The following is a description of a gene set: studied in species Homo sapiens Human Gene Set: GOBP_ENZYME_LINKED_RECEPTOR_PROTEIN_SIGNALING_PATHWAY The series of molecular signals initiated by an extracellular ligand binding to a receptor on the surface of the target cell, where the receptor possesses catalytic activity or is closely associated with an enzyme such as a protein kinase, and ending with the regulation of a downstream cellular process, e.g. transcription., and this is the list of marker genes: HDAC6, GIPC1, CDK5R1, MIR519D, PIK3R1, NRTN, USP9X, SH2B3, FGFR2, BLK, PDGFRA, EP300, CD109, MIR296, SH3GL2, NDN (necdin, MAGE family member), BLVRB, BCAR1, ZDHHC16, TRIM33, CCBE1, STAP1, NPPC, ERCC2, USP9Y, DLX3, PHIP, GRB14, IL1R1, LRIT3, IGF1, PLCG1, IGFBP4, CCN3, PDE6H, EFNB2, FSTL5, FOXD1, RALB, FBXW7-AS1, ADRA2A, HIP1R, SFRP4, KCP (NCBI Gene Id 378173), ERRFI1, CEACAM1, RNF115, SOCS1, ING2, ELAPOR2, SMAD3, PAK2, SHC4, ILK, FRS2, KL, ARID4A, FGF17, AP3S1, LEMD3, MIR885, FERMT1, EPHA1, FARP1, HTRA1 (HtrA serine peptidase 1), GIGYF1, GHRL, MIR146A, RET, KIT, ADIPOQ, CSRNP1, WNT5A, MIR497, MIR149, SDCBP, SPRED1, ENG, WWTR1, ZMIZ1, NPTN, TMEM204, ADAMTS12, FGFBP3, RASA1, SFRP1, PIK3R3, PIAS2, MIR29B1, SMAD7, CYFIP2, ACP4, ERBIN, MYO1E, MIR1271, WNT1, SNX25, GHR, CD3E, COL4A3, PIK3CD, MIR101-1, FOS, MTSS1, FST, NAMPT, TGFBRAP1, FAM89B, BRAF, SMOC2, RAB14, CEP57, TBX20, KDR, DAND5 (DAN domain BMP antagonist family member 5), LRRC32 (leucine rich repeat containing 32), RGMA, MEGF8, MYORG, WFIKKN2, ZYX, VEGFC, SOSTDC1, FOXO1, GSK3B, RTN4, ETV2, RAF1, HIVEP1, MAP3K7, FOXO4, C1QTNF12, CRIM1, SHCBP1, MIR210, HSPA5, IL12B, PDGFD, USP15 (ubiquitin specific peptidase 15), RYK, HFE, GRB10, PDE6G, MIR23A, LIFR (LIF receptor subunit alpha), MSTN, GUCY2F, JAK1, CYFIP1, VAV1, RHOQ, RABGEF1, HIF1AN, NR2F2, AKT2, FOLR1, RAB7A, SHH, MYOC, RPS6KB1, IL1B, PTPRF, JCAD, FGF16 (fibroblast growth factor 16), DACT2, RBPMS, TGFA, DLX5, GALNT3, PXN, TSC22D1, SH2B1, ARHGEF7, SESN3, PDGFRL, MIR424, BDKRB2, FYN, ANKS1B, TRIB3, EFS, NUS1, RBBP4, CD8B, FLT3, FGF6, SHISA2, ACVR1C (activin A receptor type 1C), SMAD5-AS1, IL17F, HIPK2, GDF11, VWA2, MIR26A1, MIR140, CSF1, IFT80, FGFBP1, PRDM14, ABL1, SIRT1, TYK2, EPHA10, RPS6KB2, PIP4K2C, NEDD4, ENPP1, CADM4, ZNF8, UCMA, FGF20, FKBP8, COL1A1, HNF4A, ZEB2, ZNF703, CNKSR1, SREBF1, MAPKAPK3, MIR183, XBP1, PILRB (paired immunoglobin like type 2 receptor beta), SELENON, ARRB2 (NCBI Gene Id 409), NKX3-1 (NCBI Gene Id 4824), ONECUT2 (NCBI Gene Id 9480), NPR1 (NCBI Gene Id 4881), PDGFB, FGF2, SULF2, MMP14, SLC39A14, VEPH1, MIR181A2, PML, KLB, FGF8, FGF12, HGF, TMEM100, INHBA, MTCL2 (microtubule crosslinking factor 2), HGS, SAMD10, MSX1, SAP30 (NCBI Gene Id 8819), PROX1, STAT6, SAMD12, MUSK, POLR1G, CAV2, ARK2C, MIR573, MVB12B, TGFB3, GDF7, TRIM71, GRB7, CSH1, EFNA4, PPM1L, MEN1, CTDSPL2, GPER1, PHF14, ADAMTS3, IFI6, WFIKKN1, VEGFA, PRICKLE1, SMURF1, NODAL, NEDD9, AKT1, SOST, DUSP3, FERMT2, AGR2, SNX5, PTPRE, PIN1, LRP1, HSPB1, ZNF451, NUP93, NCOA5, FGF4, TMEM119, ZEB1, MAPKAPK2, MIR98, UBASH3B, BCL9, NRP2, TGIF2, AGTR2, CCN2, CAV1, MIR1224, IGF2R, PIP4K2B, BDNF, SMARCC1, RBBP7, TGFBR3, HES5, ABI1, TSPAN9, ITGB1, APC, FBXW7, TGFBR3L, ERBB4, ARID5B, PRKCD, MIR498, GHSR, SPRY4, PIP4K2A, BLNK, IL31RA, FAM83B, APOA1, SPRY2, BMP4, PTP4A3 (protein tyrosine phosphatase 4A3), FGF23, TAB1, NRG4, HHEX, MIRLET7B, MBD5, MIR27B, TSC2, ZC3H3, ADISSP, NHERF1, TGFB2, MMRN2, MIR564, MIR373, PLAUR, CD4, GAREM1, NRROS, LRP2, DLX1, LEPROT, PIK3CB, SPTBN1, MTOR, COL4A5, HRAS, NTRK3, LONP1, RAPGEF2, EPHB1, HTRA4, GFRA4, BRMS1, GLG1, PPP2R5B, PARP1, STXBP4, SNCA, CSF1R, APPL1, JAK2, SLC2A10, CSHL1, FGF21, LATS1, VEGFD, TWSG1, ALKAL1, IGFBP3, CDH13, TYRO3, NLK, CASS4, GAB2, SKOR1, GP6, KIF16B, BMP2, CSH2, BRMS1L, SH2B2, RNF111, PDK2, NTRK2 (NCBI Gene Id 4915), CCN1, PIK3C2A, TGFBR1, CDKN1C, EPHA7, EFEMP1, PTPN2, GAB4, MIR19B1, MYO1C, SLC27A4, SMURF2, TNXB, GPRC5A, RAC1, INS, AKT1S1, LCK, EFNA5, SFRP2, EPHB6, ADGRG1, NTF3, DCN, EGR1, FOXC1, STK11, CLNK, SPG21, CER1, SMAD9, PDK4, FSTL1, DSTYK, GCNT2 (NCBI Gene Id 880), NHERF4, EFNB3, MIR205, MIR199B, TET1, SLC2A4, IRS1, CHRDL2, RUNX2, DAB2, GFRA3, ALKAL2, DOK5, VAV2, CSF2RA, PRMT1, SINHCAF, ZDHHC17 (zinc finger DHHC-type palmitoyltransferase 17), LCP2, TMEM53, IL6ST, LEP (NCBI Gene Id 3952), SOCS2, NRG3, MMP2, HIP1, DDX5, CDKN2B, SRMS, TGIF1, SERPINA12, VTN, ID1, EREG, EGF, TIE1, CSNK2B, KALRN, DOK2, ACVR2B, TTK, IL17RD, SCX, IL12A, BAMBI, FZD1, AXL, SAP30L, EPHA5, APOD, ZNF423, INSR, FGFR3 (NCBI Gene Id 55546), CD7, CCDC88A, MAPK3, CAV3, NCK2, DDR1, LRIG2, EGFR, DBX2, HSPA1A, GDF10, ZGPAT, LIF, EFNA2, VPS13A, GUCY2D, OFD1, MTMR4, EIF2AK3, ITGB3, AHI1, HPGD, ARF4, PTPRR, JUN, MMP9, PMEPA1 (prostate transmembrane protein, androgen induced 1), MIR361, MAPK1, MIR638, DSG4, NUMA1, PEG10, IGF2, FGF14 (NCBI Gene Id 317685), TMPRSS6, FFAR3, FLRT1, PRLR, PBLD (NCBI Gene Id 64081), MET, PAK3, SNX6, VWC2, RHBDF1, ITGA8 (integrin subunit alpha 8), ITGA5, PDCD4, HAP1, GPC1, NUCKS1, AMH, WASF1, GFRA1, MIR29C, MIR103A1, NR4A3, TFAP2B, GH1, TIAM1, FGFRL1, PTN (pleiotrophin), ERBB3, PPARG, EPN2, SRC, RGS14, DKK1, GDF2, SH3TC2 (NCBI Gene Id 79628), SOCS4, STON1, INPPL1, TGFBR2, RBM4, PDGFRB, GATA4, NDRG4 (NCBI Gene Id 65009), CTNNB1, MIR490, MZB1 (marginal zone B and B1 cell specific protein), FGF7, LTBP2, SOCS3, PTPRJ, CRIPTO3, CFC1B, NRXN1, RGCC, SORT1, EPHB4, NUP62, EID2, CITED1, ARNT, ROR1 (receptor tyrosine kinase like orphan receptor 1), EPHA8, MIR93, PIK3R2, MIR520C, SOS2, MAPK14, FGF9 (NCBI Gene Id 2254), RHBDF2 (NCBI Gene Id 79651), CRK, HIF1A (NCBI Gene Id 3091), BECN1, SPRY1, PTPRD, GHRHR, COL4A6, FKBP1C, PTPRT (protein tyrosine phosphatase receptor type T), GSK3A, APLN, LATS2, NDP, INTS9, ZNF592, RAPGEF1, CBLB, PRDM16, ING1, PDPK1, ZFYVE9, PTPN1, MIR204, TNFAIP6 (NCBI Gene Id 7130), HOXA13, LOX, ADIPOR1, GREM2, CIDEA, MYOCD, NCL, MIR323A, MIR372, FGF5, EFNB1, PSG9, EIF4EBP2, STAT3, SLC2A8, AKAP4, SKI, MMRN1, PSPN, GDNF, RELA, ANGPT1, MIR30A, GFRA2, NOG, SOCS7, ATXN1, GLCE, DOK1, CD63, IRS2, ZMIZ2, CBL, ABL2, ALK, SH2D6, FAM83G, TGFB1, SYK, GUCY2C, NTRK1, APPL2, HRG, NR1H4, VPS25, SHOC2, PTPN18, COL1A2, F3, DDR2, FOXC2, FZD4, NOTCH1, TXNIP, CD8A, ATOH8, COL4A1, PTPN12, CFC1, LPXN, GAS6, NGF, SKOR2, ACVR1, MICOS10-NBL1, PTPRG, SMAD2, FURIN, FUT8, MIR10B, SHC2, AR, LEPROTL1, IFT20, HCK, MIR142, ROR2, DOCK3, SEMA6A, DAB2IP (DAB2 interacting protein), GDF15, NPPB, HDAC2, EPHA2 (NCBI Gene Id 1969), F7, TEK, IQGAP1, MSX2, MIR302C, EXT1, PTPRK, TNS2, SMPD3, PALS1, FGF18, BCAR3, ESM1, FBXL15, PAK1, FGF10, BTC, IRS4, DMRT1, PDGFC, DGKQ, LYN, FSTL3, IGFBP2, BMPR1B, SMAD1, TRIM72, PGF (placental growth factor), MAP2K1, CREB1, FUZ, BCL9L, OGT, PRKAA1, PRKD2, NGFR, YES1, AKAP3, RNF126, GDF9, AFAP1L2, ROBO1, SLC39A5, IGFBP5, ASPN, FBXW8, SOX11, CNOT9, SNW1, GKAP1, MIRLET7A1, FGF19, HDAC1, ADAMTSL2, DOK7, PTPRU, AQP5-AS1, GREM1, EPHA6, SUDS3, NGLY1, SMAD5, NKX2-1, VIL1, LDLRAD4, GNG7, CD2AP, CTSD, MIR21, MIRLET7G, FGFR4, TSG101, MIR329-1, FIBP, VWC2L, MIR18A, STAT5B (NCBI Gene Id 6777), SPRED2, LRG1, BMPER, HHIP, ERBB2, KANK1, ROS1, SAP130, ZFYVE27, GPC3, PIGR, MIR30B, SLC30A10, PELO, ANGPT2, POU5F1, NFIA (nuclear factor I A), FGF1, CDH3, SIN3A, MIR125B1, MIR27A, AHSG, SGPL1, LTK, VASN, GRB2, ADAM9, MIR342, TIPARP, FLT4, GDF3, SHKBP1, GDF6, REPS2, ZBTB7A, AMHR2, GATA3, FBN1 (NCBI Gene Id 7470), ZBTB7B, SPI1, IDE, FER, FGFR1, ECSIT, ZFAND2B, MVP (major vault protein), DGKD, CHMP6, COL3A1, CHRDL1, SMAD4, LEF1, NDEL1, MIR221, MAPKAP1, PTK2, NTF4, ERO1A, CHN1, CREBBP, FASLG, HESX1, NRG1, CUL5, LEFTY1, GUCA1B, RBPMS2, CASP3, JAK3, PDGFA, THBS1, EPHB3, RARRES2, TBX2, PID1 (NCBI Gene Id 55022), RBX1, MIR302B, UBE2O, CHURC1, MIR15B, SORBS1, ITGB5, FSHB, MIR212, MIR200C, ITGB6, ADGRA2, MIRLET7F1, FNTA (NCBI Gene Id 2339), STRAP, RHOD, CILP, NFATC4, WDR54, PRKCB, AGT, EPHA3, FSHR, INSRR, MERTK, SORL1, ITGB8 (NCBI Gene Id 3696), LGMN, CPNE3, BMP6, SVEP1, EFNA3, ARTN, MIR29A, GFRAL, CRB2, LTBP1, IGSF1, MST1R, WNT4, ATF2, GIGYF2, XIAP, TP53, BAIAP2, MT3, STAT5A, PLCB1, SHC1, PRKD1, FBN2, OSBPL8, NREP, ERCC1, SOS1, MIR214, GDF5, BMP5, NOMO3, RGMB, ITGA3, FRK, PLAT, NOTCH2, ERFE, GRAPL, CUL7, HSP90AB1, GPR155, EFNA1, ITGA1, MAP2K2, NPPA, MIR503, NOMO1, MIR19A, FLT1, MIR26B, DKK3, TSKU, FLCN, CSPG4, BMPR1A, AREG, FLRT3, OTX2, FSTL4 (follistatin like 4), MIR100, SULF1, NRG2, MIR145, PTK6, PTPN3, FGF22, NPR2, DDIT4, UBE2D3, HJV (NCBI Gene Id 9974), SOCS5, TRAT1, SPART, SIPA1L1, FKBP1A, MIR1-1, BMP7, FGF3, PIK3CA, RALA, PLCE1, HBEGF, VEGFB, MIR483, CITED2, NDST1, GHRH, GIT1, CBLC, ZNF106, PCSK6, HES1, DLL1, GPLD1, ANKS1A, PPARA (peroxisome proliferator activated receptor alpha), TRIO, TGFB1I1, DUSP22, MIR199A1, KIAA0319, CHST11, ANGPTL1, FAM20C, PALM2AKAP2, FOXH1, FRS3, DOK3, CRIPTO, MIR20A, MIR130A, COL4A2, INPP5K, PDCD6, INHBB, ACVR2A, CLDN5, STUB1, OVOL2, PPM1A, SCUBE3, TOB1, MIR10A, MIR17, DOK4, NPNT, EPHB2, EPGN, SMAD6, EPHA4, FMOD, NBL1, CLEC14A, CRKL, MAP1LC3A (NCBI Gene Id 84557), NCLN (NCBI Gene Id 95376), RASL11B, MVB12A, NEO1, PRKCZ, MIR9-1, CSRP3, SS18, FUT7, UBE2D1 (NCBI Gene Id 9335), DNAI1, TSPAN32, ADAM17, CAMLG, ACVR1B, RBPJ, PTGIR, MIR106A, SOX9, CDH5 (cadherin 5), MECOM, ONECUT1, SPRY3, FLRT2, IGFBP1, ZFAND5, C2CD5, SLC31A1, IGF1R, MPZL1, MAP2K5, PTPN11, AXIN1, FAM83A, GH2, GAB1, CHRD, ZFYVE28, NGEF, MUC20, CLASP2, EMILIN1, BMPR2, LTBP3, PLEKHA1, HTRA3, STMN1, MIR107, NRP1 (NCBI Gene Id 8829), MIR195, SKIL, GPR21, NEU3, PTK2B, LRP4, MAGI2, TRADD, FGR, DACT1, CREB3L1, BMP10, ACVRL1, DOK6, MIR376C (microRNA 376c), MIR133A1, PRKCQ, COMP, TMEM108 (NCBI Gene Id 66000), SIK2, LTBP4, NCK1, MIR16-1, ARHGEF28, IGFBP6, SHC3, COL6A1, SPRED3, ARID4B, GOT1